The following is a description of a gene set: part of: Drug resistance of FLT3 mutants Reactome Pathway: sunitinib-resistant FLT3 mutants Sunitinib is a first generation type II tyrosine kinase inhibitor with broad specifity for receptor tyrosine kinases, including FLT3. This pathway describes FLT3 mutants that show resistance to sunitinib-mediated inhibition. studied in species Homo sapiens, and this is the list of marker genes: FLT3 (NCBI Gene Id 2322)